The following is a description of a gene set: from publication Chen Y, Wang X (PMID 31504780) species: Mus musculus Mouse Gene Set: MIR_8120 Genes predicted to be targets of miRBase v22 microRNA mmu_miR_8120 in miRDB v6.0 with MirTarget v4 prediction scores > 80 (high confidence targets)., and this is the list of marker genes: Myct1, Uevld, Kras, Luc7l3, Cxcl3 (NCBI Gene Id 330122), Gsk3b, Ube3a, Cnrip1, Ppp1r7, B3gat3 (NCBI Gene Id 72727), Igsf10, Nanos1, Csn1s1, Nrg3, Atf2, Syap1, Rrh, Ube2j1, Cacnb4, Hnrnph1, Clmp, Ago1, Pnisr, Rsrc2, Tmem255a, Emx2 (NCBI Gene Id 13797), Nexmif, Tbc1d12, Rora (RAR-related orphan receptor alpha), Baz2b, Ttc33, Col8a1, Zfp811, Dcaf5, Capn3 (NCBI Gene Id 98918), Syt1, Chd6, Vwa3a, Slc44a3 (solute carrier family 44, member 3, NCBI Gene Id 213603), Foxn3, Kdm3b, Dyrk1a, Cpne4 (NCBI Gene Id 74020), Tapt1, Dctn4, Ugt2b5, Serp1, Gnrhr, Rnf14, Prickle3, Lrrc14b, Synj2, Wars2, Nlk, Dll1, Pank3, Dmxl2, Cacna1b, Tstd2, Pik3r5, Il1rapl2, Thsd7a, Onecut3, Mgat4d, Phox2b, Tox3, Hecw2, Tmem30b, Nrxn1, Lrrc55, Ptpn4, Hectd1 (HECT domain E3 ubiquitin protein ligase 1), Cdk14, Mfsd4b5, Nol4l, Uri1, Chn1, Slc19a2, Trim16, Asxl2, Fam219b, Map1lc3b, Klf6, Zbtb7a, Tbl1xr1, Brd1, Pnrc1, Rph3al, Tnk1, Surf4